Given this list of marker genes Msn, Gnb5, Pkp2, Rgs11, Lrit3, Rab8b, Slc3a2, Trpm1, Astn2, Trf, Grm6, Des, Rdx, Slc32a1, Ezr, Pex5l, Vangl2, Pi4k2a, Rgs7, Gpr179, here is a description of the gene set: studied in species Mus musculus Mouse Gene Set: GOCC_CELL_POLE Either of two different areas at opposite ends of an axis of a cell.